The following is a description of a gene set: Human Gene Set: MIKKELSEN_PARTIALLY_REPROGRAMMED_TO_PLURIPOTENCY Genes up-regulated in cells that have been partially reprogrammed to pluripotency: comparison with the parental lineage-committed cell lines, fully reprogrammed stem cells, and embryonic stem cells. Somatic cells can be reprogrammed to a pluripotent state through the ectopic expression of defined transcription factors. Understanding the mechanism and kinetics of this transformation may shed light on the nature of developmental potency and suggest strategies with improved efficiency or safety. Here we report an integrative genomic analysis of reprogramming of mouse fibroblasts and B lymphocytes. Lineage-committed cells show a complex response to the ectopic expression involving induction of genes downstream of individual reprogramming factors. Fully reprogrammed cells show gene expression and epigenetic states that are highly similar to embryonic stem cells. In contrast, stable partially reprogrammed cell lines show reactivation of a distinctive subset of stem-cell-related genes, incomplete repression of lineage-specifying transcription factors, and DNA hypermethylation at pluripotency-related loci. These observations suggest that some cells may become trapped in partially reprogrammed states owing to incomplete repression of transcription factors, and that DNA de-methylation is an inefficient step in the transition to pluripotency. We demonstrate that RNA inhibition of transcription factors can facilitate reprogramming, and that treatment with DNA methyltransferase inhibitors can improve the overall efficiency of the reprogramming process. species: Mus musculus from publication Mikkelsen TS, Hanna J, Zhang X, Ku M, Wernig M, Schorderet P, Bernstein BE, Jaenisch R, Lander ES, Meissner A (PMID 18509334), and this is the list of marker genes: PERP, CDKN1A, SLC38A5, CDH13, SYNE2, CCND1, PHOX2B, TFAP2A, CDKN2A, FOXD1